Given this list of marker genes Gpm6a, Gpr141b, Prkca, Grhl1, Cacna1b, Btaf1, Cenpw, Ufl1, Tceal8, Capn6, Cplx4, Nkiras1, Fam216a, Adam18, Klf6, Gucy1a2 (guanylate cyclase 1, soluble, alpha 2), Dzank1, Pik3c2g, Cacna1a, Arhgap36, Gpatch11, P2rx3, Lrrc28, Pds5b, Tsga10, Nbeal1, Pate6, Esp36, Abi3bp, Erbb4, Tfcp2, Zfp804a (zinc finger protein 804A), Cav1, Ccdc88a, Esr1, Mex3c, Mblac2, Cry1, Nhlrc2, Fam149b, Rcbtb1, Clvs2, Glt8d2, Rab21, Or51ab3, Vcl, here is a description of the gene set: studied in species Mus musculus Genes predicted to be targets of miRBase v22 microRNA mmu_miR_3074_1_3p in miRDB v6.0 with MirTarget v4 prediction scores > 80 (high confidence targets). from publication Chen Y, Wang X (PMID 31504780) Mouse Gene Set: MIR_3074_1_3P